The following is a description of a gene set: studied in species Homo sapiens Any process that decreases the frequency, rate or extent of endopeptidase activity, the endohydrolysis of peptide bonds within proteins. Human Gene Set: GOBP_NEGATIVE_REGULATION_OF_ENDOPEPTIDASE_ACTIVITY, and this is the list of marker genes: CRB2, SERPINB8, FETUB, RECK, CR1, SPOCK2, SERPINB3, GAPDH, SERPINB9, SERPINB1, SPOCK3, TIMP1, SERPINB13